Given this list of marker genes CDKN1A, CDKN2B, ATRX (NCBI Gene Id 6475), NLGN4X, SHROOM4, NLGN3 (NCBI Gene Id 54413), MECP2, CDKN1B, TDO2, SNRPN (NCBI Gene Id 6638), SDHD, MEN1, CDKN2C, here is a description of the gene set: Human Gene Set: HP_INCREASED_SERUM_SEROTONIN studied in species Homo sapiens Increased serum serotonin A increased concentration of serotonin in the blood.